Given this list of marker genes Snrpa1, Ro60, Sf3b3, Isg20, Prpf8, Coil, here is a description of the gene set: Binding to a U2 small nuclear RNA (U2 snRNA). Mouse Gene Set: GOMF_U2_SNRNA_BINDING studied in species Mus musculus